Given this list of marker genes Atf5, Rac1, Slit2, Sall3, Robo1, Fgfr1, Robo2, Wnt5a, Arx, here is a description of the gene set: Mouse Gene Set: GOBP_OLFACTORY_BULB_INTERNEURON_DEVELOPMENT species: Mus musculus The process whose specific outcome is the progression of an interneuron residing in the olfactory bulb, from its initial commitment, to the fully functional differentiated cell.